Given this list of marker genes LRRC8E, CAMKK1, GRIK5, PPP1CA, ADCY8, TNF, PRKCA, CNTF, NOS1, DISC1, SLC17A6 (NCBI Gene Id 57084), SLC38A2, CAMK2A, PLCB3, PSAT1, CFL1, GRIK4, IL1A, INSR, GRIK1, SHMT2, TGFB1, GRIN3A, CAMK2B, BDNF, DLD, AKT1, GRM8, PRKCB, IL1B, IL10, MAPK3, SMAD2, IL12A, TRPM4, GFAP, ADCY1, IL1R2, LRRC8A, CAMK4, PRKACA, LRRC8C, SLC1A3, SMAD4, TGFBR1, SLC7A10, LIF, SHMT1, IL10RA, GRIA2, TGFBR3 (NCBI Gene Id 7049), GRIN2D, SLC2A1, SOCS3, SLC1A4, IL6R, SLC38A1, LTA, SLC38A3 (solute carrier family 38 member 3), GRIK2, ARC, SLC17A7, CREB1, PLCB4, SLC1A6, GRIK3, GRIN2C, PDHA1, SLC1A1, IGF1, SMAD3, CALM1, GRM5 (NCBI Gene Id 2915), SLC2A3, ADCY3, PSPH, IL6, GRIA1, IFNGR2, STAT6, PHGDH, TGFB3, TRAF5, JAK1, NFKB1, TNFRSF1A, PPP1CB, IL10RB, IL13, DAO, STAT1, IL1R1, CAMKK2, LRRC8D (leucine rich repeat containing 8 VRAC subunit D), GRIA3, MAPK1, CAMK2D, GLS2, CAMK2G, GRIA4, IL6ST, SLC6A9, IL4R, GRIN1, SLC38A5, NGF, IFNGR1 (NCBI Gene Id 3459), NFKB2, GLS (NCBI Gene Id 51679), GRIN2A, GRIN3B, IL12B, IL13RA1, STAT3, PLCB1, IFNG, IL4, TGFB2, TGFBR2, LRRC8B, GRM1, SMAD7, SRR, GRM7, PLCB2, DLAT (dihydrolipoamide S-acetyltransferase), GRIN2B, FGF2, BCL2 (NCBI Gene Id 596), NSMF, PRKCG, IRS1 (insulin receptor substrate 1), GOT1, FOS, SLC1A2, GLUL, PPP1CC, GRM2, GRM4, TNFRSF1B, here is a description of the gene set: Human Gene Set: WP_NEUROINFLAMMATION_AND_GLUTAMATERGIC_SIGNALING studied in species Homo sapiens Neuroinflammation and glutamatergic signaling